Given this list of marker genes ASIC2, RELN, CDH2, LATS1 (large tumor suppressor kinase 1), CYFIP2, GRID2, DOCK4, CC2D1A, LRRC4B, C1QL3, HTR4, ZDHHC12, NRXN1, GAP43, WNT7A, RHOG, WNT5A, LRRTM2, CSMD2, NLGN2, MARK1, PTK2B, ELMO1, RTN4R, VPS35, CARMIL3, CASKIN1, NECTIN3, NTNG2, PTPN1 (NCBI Gene Id 5770), NAE1, SPTBN2, PTPRD, SLITRK3, NCKIPSD, PTEN, ARHGAP33, SEMA4C, TRIM47, RAC1, NRXN2, LRP4, ARHGEF9, CRK, CBLN1, MAP1B, SHANK3, EPHB2, SENP1 (NCBI Gene Id 29843), CRMP1, NLGN1, UBE2M, LZTS1, NEURL1, PUM2, SLC12A5, CRIPT, LRFN4, FGFR1, ARHGEF15, ABL1, DOCK1, CRKL, NEDD8, NLGN3, PPP1R9B, ZDHHC8, RAC3, C1QL2, NTRK3, DOCK10, SIGMAR1, NUMBL, ASIC1, IL1RAP, ABI3, PRICKLE1, GNA13, UBE3B, LRFN1, PTPRS, SYNDIG1, ARHGAP12, S1PR2 (sphingosine-1-phosphate receptor 2), NPTX1, RTN4, here is a description of the gene set: Human Gene Set: GOBP_POSTSYNAPSE_ASSEMBLY studied in species Homo sapiens The aggregation, arrangement and bonding together of a set of components to form a postsynapse.